Given this list of marker genes PPIF, TRPV4, MACROH2A1, IFNLR1, SHMT2, ACTN3 (actinin alpha 3), ETFRF1, PRELID1, ENSG00000293600, SLC25A23, MIR210, ISCU, ARL2, IL4, MLDHR, ATP7A, CBFA2T3, AK4 (NCBI Gene Id 387851), VCP, NOP53, OPN3, TEFM, CISD1, RHOA, SIRT3, PARK7, DNAJC15, UQCC2, NOS2, PRDM16, IFNAR1, IFNG, SNCA, IL10RB, OAS1, NUPR1, TRAP1, ABCD1, IDE, SLC25A33, MLXIPL, PIK3CA, TREX1, PNPT1, TMEM135, PINK1, TNF, here is a description of the gene set: species: Homo sapiens Any process that modulates the frequency, rate or extent of cellular respiration, the enzymatic release of energy from organic compounds. Human Gene Set: GOBP_REGULATION_OF_CELLULAR_RESPIRATION